Given this list of marker genes Il15ra, Il2rg, Sos1, Shc1, Stat3, Grb2, Stat5b, Il15, Il2rb, Stat5a, Sos2 (SOS Ras/Rho guanine nucleotide exchange factor 2), here is a description of the gene set: studied in species Mus musculus Mouse Gene Set: REACTOME_INTERLEUKIN_15_SIGNALING Interleukin-15 signaling